Given this list of marker genes Psmd6, Psma5, Psmd13, Psmb6, Psma1, Psma3, Psmc6, Ubb, Psmd12, Psmd7, Rps27a, Psmb4, Fbxl7, Psmc4, Cul1, Psmc2, Psmc5, Psma2, Psma6, Psmc3 (proteasome (prosome, macropain) 26S subunit, ATPase 3), Psmb5, Psma4, Psmb7, Psma7, Psmd1, Psmc1, here is a description of the gene set: electronically inferred by orthology from the curated human pathway studied in species Mus musculus This event has been computationally inferred from an event that has been demonstrated in another species.<p>The inference is based on the homology mapping from PANTHER. Briefly, reactions for which all involved PhysicalEntities (in input, output and catalyst) have a mapped orthologue/paralogue (for complexes at least 75% of components must have a mapping) are inferred to the other species. Reactome Pathway: FBXL7 down-regulates AURKA during mitotic entry and in early mitosis part of: G2/M Transition